Given this list of marker genes Mecp2, Mir361, Bmp4, Ripk1, Il6, Bcdin3d, Tgfb1, Hnf1a, Dgcr8, Trub1, Lin28b, Zc3h10, Tarbp2, Trp53, Prkra, Zmpste24, Lin28a, Stat3, here is a description of the gene set: studied in species Mus musculus Mouse Gene Set: GOBP_REGULATION_OF_REGULATORY_NCRNA_PROCESSING Any process that modulates the frequency, rate or extent of regulatory non-coding RNA processing.